Given this list of marker genes Gnb1, Rxfp2, Itgb1, Crhr2, Taar8b, Gphb5, Rln1, Fn1, Gng8 (guanine nucleotide binding protein (G protein), gamma 8), Gpr84, Calca, Pth2r, Ptgir, Pde1b, Gcg, Vipr1, Pde4a, Gpr20, Gcgr, Ptger2, Taar3, Pde7a (phosphodiesterase 7A), Cga, Taar9, Gpha2, Prkacb, Adm, Calcb, Gpr83, Ghrhr, Gipr, Adcyap1r1, Pth2, Gpr176, Gng3 (NCBI Gene Id 14704), Mc1r, Gngt1, Adcyap1, Gnb2, Pde7b, Gng2, Avpr2, Htr4, Taar6, Prkar1a, Gng7, Insl3, Nps, Adrb1 (adrenergic receptor, beta 1), Calcrl, Pde1a, Gnas, Gpbar1, Hrh2, Sctr (NCBI Gene Id 319229), Ptger4, Gpr45, Gper1, Gpr39, Prkar1b, Grk6, Pde4c, Grk5, Itga5, Mc2r, Shc1, Pth, Calcr, Iapp, Tshb, Gpr150, Pthlh, Pth1r, Adrb3, Pde2a, Gpr27, Gng10, Mc5r, Htr7, Pde4d, Glp1r, Ramp3, Fshr, Lhcgr, Gnb5, Rln3, Gpr25, Ramp2, Ramp1, Tshr, Gng11, Adora2b, Crh, Npsr1, Drd5, Taar1, Gng5, Gng12, Ghrh, Pde8a, Mc3r, Pde3a, Lhb, Mc4r, Crhr1, Pomc, Htr6, Grk3, Adrb2, Taar2, Taar5, Drd1, Fshb, Gpr15, Taar8c, Pde11a, Adora2a, Sct, Rxfp1, Ptgdr, Grk2, Gip, Glp2r, Arrb1, Gngt2, Prkaca, Gng4, Adm2, Gnb3, Gnb4, Vipr2, Avp, Arrb2, Pde8b, Vip, Gng13, Pde10a, here is a description of the gene set: Mouse Gene Set: REACTOME_G_ALPHA_S_SIGNALLING_EVENTS studied in species Mus musculus G alpha (s) signalling events